Given this list of marker genes PROS2P, EPHA3, ENSG00000212598, RNU6-873P, ENSG00000288654, CHMP2B, ZNF654 (NCBI Gene Id 84158), C3orf38, GAPDHP50, MTCO1P6, MIR4795, ABCF2P1, APOOP2, PSMC1P6, POU1F1, CBX5P1, NDUFA5P5, RNU6ATAC6P, HTR1F, CSNK2A2IP, RNU6-712P, KRT8P25, ICE2P2, CGGBP1, ENSG00000239572, MTCO2P6, HSPE1P19, here is a description of the gene set: Human Gene Set: chr3p11 studied in species Homo sapiens